The following is a description of a gene set: An abnormality of the antitragus, which is a small tubercle opposite to the tragus of the ear. The antitragus and the tragus are separated by the intertragic notch. studied in species Homo sapiens Human Gene Set: HP_ABNORMAL_ANTITRAGUS_MORPHOLOGY Abnormal antitragus morphology, and this is the list of marker genes: KCTD1, PIGK, COL2A1, PNPLA6, FN1, B3GAT3, PGM2L1, KAT6A, CHST3, RAB3GAP2